Given this list of marker genes OPN1LW, here is a description of the gene set: studied in species Homo sapiens Reactome Pathway: Defective visual phototransduction due to OPN1LW loss of function part of: Retinoid cycle disease events Blue cone monochromatism (BCM) is a rare X-linked congenital cone dysfunction characterized by the absence of functional long wavelength-sensitive (red) and medium wavelength-sensitive (green) cones in the retina. Colour discrimination is severely impaired from birth, and vision is derived from the preserved short wavelength-sensitive (blue) cones and rod photoreceptors. BCM typically presents with reduced visual acuity, pendular nystagmus, photophobia and patients often have myopia. BCM affects approximately 1 in 100,000 individuals and can be caused by loss-of-function mutations in the <i>OPN1LW</i> gene (see review Gardner et al. 2009).<br><br>Defects in OPN1LW also cause partial colorblindness, protan series (CBP, protanopia; MIM:303900) due to non-functional red cones.